The following is a description of a gene set: Enables the transfer of lactate from one side of a membrane to the other. Lactate is 2-hydroxypropanoate, CH3-CHOH-COOH; L(+)-lactate is formed by anaerobic glycolysis in animal tissues, and DL-lactate is found in sour milk, molasses and certain fruit juices. Human Gene Set: GOMF_LACTATE_TRANSMEMBRANE_TRANSPORTER_ACTIVITY studied in species Homo sapiens, and this is the list of marker genes: SLC16A7, SLC16A8, SLC5A8, SLC5A12, SLC16A3, SLC16A1